The following is a description of a gene set: Binding to an adenosine receptor. Mouse Gene Set: GOMF_ADENOSINE_RECEPTOR_BINDING studied in species Mus musculus, and this is the list of marker genes: P2ry1, Necab2, P2ry2, Grm5, Tsnax, Hspa8, Usp4